The following is a description of a gene set: An actin-rich cytoskeletal network located beneath the microvilli of the apical plasma membrane of polarized epithelial cells. In addition to actin filaments, the terminal web may contain actin-binding proteins, myosin motor proteins, and intermediate filaments. The terminal web can function as a contractile structure that influences the spatial distribution of microvilli as well as the development and morphogenesis of tissues containing polarized epithelial cells. studied in species Mus musculus Mouse Gene Set: GOCC_TERMINAL_WEB, and this is the list of marker genes: Cobl, Vcl (NCBI Gene Id 268722), Pls1, Hfe, Krt19